The following is a description of a gene set: Mouse Gene Set: GOMF_OXIDOREDUCTASE_ACTIVITY_ACTING_ON_THE_ALDEHYDE_OR_OXO_GROUP_OF_DONORS_OXYGEN_AS_ACCEPTOR Catalysis of an oxidation-reduction (redox) reaction in which an aldehyde or ketone (oxo) group acts as a hydrogen or electron donor and reduces oxygen. species: Mus musculus, and this is the list of marker genes: Adh7, Aox4, Hao1, Aox3, Fmo5, Aox1, Aox2